The following is a description of a gene set: Human Gene Set: GOBP_FACULTATIVE_HETEROCHROMATIN_FORMATION The compaction of chromatin into a conformation that is refractory to transcription but that can be converted to euchromatin and allow transcription in specific contexts. These can be temporal (e.g., developmental states or specific cell-cycle stages), spatial (e.g., nuclear localization changes from the center to the periphery or vice versa due to exogenous factors/signals), or parental/heritable (e.g., monoallelic gene expression). In metazoa, this involves the methylation of histone H3K27. studied in species Homo sapiens, and this is the list of marker genes: BEND3, RRP8, PHF8, EED, MACROH2A1, EZH2, KDM5A, BAZ2A (bromodomain adjacent to zinc finger domain 2A, NCBI Gene Id 23525), SMARCA5, SUZ12, SIRT2, JARID2, SUV39H1, SIRT1, H1-2, EHMT1, PHF2